The following is a description of a gene set: Any process that activates or increases the frequency, rate or extent of CD4-positive, alpha-beta T cell proliferation. species: Mus musculus Mouse Gene Set: GOBP_POSITIVE_REGULATION_OF_CD4_POSITIVE_ALPHA_BETA_T_CELL_PROLIFERATION, and this is the list of marker genes: Cd55, Irgm1, Cd3e, Cd55b, Prkcq, Cd24a, Ripk2, Cd81, Cd28, Xcl1, Tgfbr2, Card11